The following is a description of a gene set: species: Mus musculus The binding activity of a protein that brings together a cytoskeletal protein (either a microtubule or actin filament, spindle pole body, or protein directly bound to them) and one or more other molecules, permitting them to function in a coordinated way. Mouse Gene Set: GOMF_CYTOSKELETAL_ANCHOR_ACTIVITY, and this is the list of marker genes: Micall1, Jup, Ank1, Bicd1, Bicd2, Insc, Gas2l2, Mark4, Epb41l3, Gas2l1, Baiap2, Map1a